The following is a description of a gene set: studied in species Homo sapiens Human Gene Set: GGCAGAC_MIR346 Genes having at least one occurence of the motif GGCAGAC in their 3' untranslated region. The motif represents putative target (that is, seed match) of human mature miRNA hsa-miR-346 (v7.1 miRBase)., and this is the list of marker genes: EIF3J, OSER1, CCDC136, TRAF7, NALF2, SF1, DNAJB3, CADM3, CSNK1D, FGF7, MBNL1, AFF2, OGT, SYT8, CSNK1G1, KCTD15, RBM39, PPP1R9B, HBP1, GRM7, FGF7P3, AGO2 (NCBI Gene Id 286109), ABCC12 (NCBI Gene Id 94160), NRBF2, CALN1, CCDC88B, KRAS, IGF2BP1, BCL6, LRRTM1, PFN2, FSTL4, MAN1C1, LRP6, SRSF10, RPS6KB2, ZFC3H1, PRICKLE2, LIF, ZNF609, COL2A1, SZRD1, PIK3R3, SMAD3